The following is a description of a gene set: studied in species Homo sapiens Human Gene Set: GOBP_PYRIMIDINE_NUCLEOSIDE_TRIPHOSPHATE_METABOLIC_PROCESS The chemical reactions and pathways involving pyrimidine nucleoside triphosphate, a compound consisting of a pyrimidine base linked to a ribose or deoxyribose sugar esterified with triphosphate on the sugar., and this is the list of marker genes: TYMS, CTPS1, CMPK2 (NCBI Gene Id 129607), UCK2 (uridine-cytidine kinase 2), NME9, UCK1, NME2P1, CTPS2, NME3, ENTPD4, DUT, UCKL1, NME1, NME7, AK3, NME2, CAD, NME4, TBPL1, ENTPD7, NME5, DCTPP1, NME6, DTYMK